Given this list of marker genes KAZN, PLAUR, CTBP2, FCAR, P2RY14, LRRK2, H3C13, IRAG1, here is a description of the gene set: Human Gene Set: CAO_BLOOD_FLUZONE_AGE_05_14YO_7DY_DN Genes down-regulated in blood 7d vs 0d in children (0.5-14y) after exposure to Fluzone, time point 7D. Comment: ~80% of cohort were white, ~50/50 Female:male species: Homo sapiens from publication Cao RG, Suarez NM, Obermoser G, Lopez SM, Flano E, Mertz SE, Albrecht RA, García-Sastre A, Mejias A, Xu H, Qin H, Blankenship D, Palucka K, Pascual V, Ramilo O (PMID 24495909) BACKGROUND: Live attenuated influenza vaccine (LAIV) and trivalent inactivated influenza vaccine (TIV) are effective for prevention of influenza virus infection in children, but the mechanisms associated with protection are not well defined. METHODS: We analyzed the differences in B-cell responses and transcriptional profiles in children aged 6 months to 14 years immunized with these 2 vaccines. RESULTS: LAIV elicited a significant increase in naive, memory, and transitional B cells on day 30 after vaccination, whereas TIV elicited an increased number of plasmablasts on day 7. Antibody titers against the 3 vaccine strains (H1N1, H3N2, and B) were significantly higher in the TIV group and correlated with number of antibody-secreting cells. Both vaccines induced overexpression of interferon (IFN)-signaling genes but with different kinetics. TIV induced expression of IFN genes on day 1 after vaccination in all age groups, and LAIV induced expression of IFN genes on day 7 after vaccination but only in children < 5 years old. IFN-related genes overexpressed in both vaccinated groups correlated with H3N2 antibody titers. CONCLUSIONS: These results suggest that LAIV and TIV induced significantly different B-cell responses in vaccinated children. Early induction of IFN appears to be important for development of antibody responses.